The following is a description of a gene set: part of: DNA strand elongation Reactome Pathway: Leading Strand Synthesis The processive complex is responsible for synthesizing at least 5-10 kb of DNA in a continuous manner during leading strand synthesis. The incorporation of nucleotides by pol delta is quite accurate. However, incorporation of an incorrect nucleotide does occur occasionally. Misincorporated nucleotides are removed by the 3' to 5' exonucleolytic proofreading capability of pol delta. studied in species Homo sapiens, and this is the list of marker genes: POLD1, RFC4, RFC2, PRIM1 (NCBI Gene Id 5557), RFC3, POLD3, POLA1, RFC1, RFC5, POLA2, POLD2, PCNA, PRIM2, POLD4